Given this list of marker genes Cer1, Nppc, Atf2, Dspp, Carm1, Por, here is a description of the gene set: studied in species Mus musculus The multiplication or reproduction of chondrocytes in a growing endochondral bone, resulting in the expansion of a cell population. Mouse Gene Set: GOBP_GROWTH_PLATE_CARTILAGE_CHONDROCYTE_PROLIFERATION